Given this list of marker genes CDK14 (cyclin dependent kinase 14), TIAM1-AS1, DSE, TNRC6B, DTX1, ATL2, DDX6, LMX1A, ADCY9, PIPOX, here is a description of the gene set: from publication Chen Y, Wang X (PMID 31504780) species: Homo sapiens Genes predicted to be targets of miRBase v22 microRNA hsa-miR-6090 in miRDB v6.0 with MirTarget v4 prediction scores > 80 (high confidence targets). Human Gene Set: MIR6090